The following is a description of a gene set: species: Mus musculus Interleukin-1 processing Mouse Gene Set: REACTOME_INTERLEUKIN_1_PROCESSING, and this is the list of marker genes: Gsdmd (gasdermin D), Il1b, Rela, Nfkb1, Il1a, Ctsg, Il18, Casp1, Nfkb2